The following is a description of a gene set: Microtubule nucleation. Pathway ID: N01544. Pathway type: Reference. Pathway class: nt06515 Regulation of kinetochore-microtubule interactions. Pathway Definition from KEGG: CDK5RAP2 == gamma-TuRC+TPX2 == ch-TOG == microtubule Human Gene Set: KEGG_MEDICUS_REFERENCE_MICROTUBULE_NUCLEATION studied in species Homo sapiens, and this is the list of marker genes: TUBB1, CDK5RAP2, TUBGCP3, TUBB8, TUBGCP6, TUBA1B, TPX2, NEDD1, TUBGCP5, TUBB2A, TUBB4B, TUBA1C, TUBGCP4, TUBB6 (NCBI Gene Id 84617), TUBB, TUBA3E, MZT2A, TUBA1A, TUBA4A, MZT2B, TUBA3C, TUBB4A, TUBB2B, TUBGCP2, TUBA8, TUBA3D, CKAP5, TUBB3